The following is a description of a gene set: from publication Pearl JI, Lee AS, Leveson-Gower DB, Sun N, Ghosh Z, Lan F, Ransohoff J, Negrin RS, Davis MM, Wu JC (PMID 21362570) Genes down-regulated in comparison of untreated CD4 T cells versus CD8 T cells treated with leukocyte costimulatory blockade antibodies. Human Gene Set: GSE26669_CD4_VS_CD8_TCELL_IN_MLR_COSTIM_BLOCK_DN To elucidate the gene expression “footprint” of antigenically challenged T-cells which had been treated with anti-LFA-1, CTLA4Ig, anti-CD40-ligand antibodies, we performed microarray gene expression analysis comparing the expression profile of costimulatory blockade treated and untreated responder T-cells. species: Homo sapiens, and this is the list of marker genes: ABHD15, LRRC40, NUP133, TBC1D21, TNFRSF1B, TOMM34, ARL4C, PRELID2, RRAS, NLRC3, PDIK1L, DOCK10, TMEM128, FRRS1, TRMT10C, PKDREJ, TRIM33, NDUFS6, KLF7, KLK8, ACP5, CRIM1, ANXA7, ST7, DDO, AKAP1, SCP2, ATP6V1H (NCBI Gene Id 51606), RAI1, EGLN3, LTK, HOOK1, HPCAL1, FRMD4A, TRIM28, PDGFRB, DNAJA4, IGFBP6, TP53I13, CALHM6, RNF152, KLHL6, PTER, RRAS2, RARG, MKX, ADCY7, TBC1D2B, LEPROTL1, FAM114A1, IPCEF1, HIPK1, ANAPC4, DDHD1, CD3E, WDR59, MEOX2, UTRN, NEDD4, B4GALNT1, NSMCE4A, CRIPTO, APOA4, KIF23, DUSP2, RNF157, PLCXD2, PLEKHO1, ARHGAP23, MGAT4A, MRPL37, TACC1, ZNF787, NR1D2, HAAO, EVC, CHSY1, CCDC117, NBEAL2, SIDT1, SLC25A4, SLC26A4, ACP3, MTERF1, CRKL, MFSD5, BCO2 (beta-carotene oxygenase 2), TAPT1, NXPH4, MBD2, PRXL2B, MRPS18B, POLA2, AKR1B10, AFDN, TNNT2, HLA-G (major histocompatibility complex, class I, G), PRRT1, CDT1, AEBP2, PLCB1, CMIP, TPST2, FMNL1, TIMP2, TRIM14, SHANK3, SLC37A3, HTR3B (NCBI Gene Id 9177), C4BPA, BIVM, PREX1, MRPL24, IFNGR1, BRINP1, PRKCB, MARVELD1, KLRC1, PSD2, EHD3, B4GALT1, RHD, RSPH3, IRF1, MED30, CDK5RAP2, DNAAF1, FXYD7, GSTO1, CAMK2B, HCST, GALNT6 (NCBI Gene Id 11226), CDK4, KLF12, CCL4, TOP3B, INSL6, GTF2IRD2, ATP11B, ZC3H12D, S100A10, TDO2, EID3, CD27, ALOX15B, COL23A1, SAAL1, AGPAT4, KLRK1, HDAC4, HOXD3, HSD17B7, GAB3, GDAP1L1, GPATCH3, GOSR1, IQSEC1, CD200R1L, GLRX5, TCF12, ARHGAP26, DSE, TRMT1L, CYP3A7, OPRD1 (opioid receptor delta 1), SYDE2, SEMA4A, ELL, EML5, RNASEL, INMT, SLC17A9, ADCY3, HLA-DOA, VSIG2, GOLM2, CCDC3, CDK9, HAUS3, LYST, DUSP19, MBLAC2, TMEM18, S1PR5, PHGDH, SCFD2, ELOVL6, HMGXB3, FUCA2, SARAF, NUP155, MTA3, TLE4, SMKR1, MTRFR, SUN2 (Sad1 and UNC84 domain containing 2), MYOZ2, RAP1GAP2, MOGS (mannosyl-oligosaccharide glucosidase)